Given this list of marker genes G3bp1, Zc3h18, Appl1, Eme2, Spty2d1, Sgsm1, Xrn1, Gpr151, Cluap1, 4933428G20Rik, Obox7, Arhgap20, Esrrg, Atf6 (activating transcription factor 6), Slc29a3, Zfy1, Igf2bp3, Eya1, Vipas39, Prnp, Rab10, Ccdc14, Zmym2, Mtpn, Tbc1d14, Synpo, Fam90a1a, Tenm2, Kdm2a, Herc6, Zfand5, Tnfaip2 (NCBI Gene Id 21928), Btk, Chmp1b, D130043K22Rik, Dll4, Rmnd5a, Armc1, Kcnk2, Ndst1, Sp4, Gdpd5, Bnip3, Tfcp2l1, Ing1, Atf2, Cntnap2, Abhd6, Gm11992, Dennd5b (DENN domain containing 5B), Ptcra, Tmem174, Cp, Rnf220, Cyp27b1, Tnfrsf19, Chfr, Uba3, Dkk2, Peg3, Tnfaip8, Gata3, Tcf7l2, Usp9x, Ttc17, Vps37a, Il17rd, Mixl1, Exoc2, Ccni, Cldn1, Tnni3k, Arid4a, Retreg1, Slc35b4, Dcun1d5, Vash2, Cnp, Clk1, Dbndd2, Vmp1, Ss18, Grb7, Sema6a, Prkar1a, Fbxw7, Rock2, Slc6a1, Adgrl2, Morc3, Osbpl1a, Kcne4, here is a description of the gene set: Mouse Gene Set: MIR_3569_3P from publication Chen Y, Wang X (PMID 31504780) Genes predicted to be targets of miRBase v22 microRNA mmu_miR_3569_3p in miRDB v6.0 with MirTarget v4 prediction scores > 80 (high confidence targets). species: Mus musculus